The following is a description of a gene set: The process whose specific outcome is the progression of the dendritic spine over time, from its formation to the mature structure. A dendritic spine is a protrusion from a dendrite and a specialized subcellular compartment involved in synaptic transmission. Human Gene Set: GOBP_DENDRITIC_SPINE_DEVELOPMENT species: Homo sapiens, and this is the list of marker genes: LRP8, MAPK6, DLG4, SIPA1L1, FSTL4, ABI3, PTEN, RELN, NCK2, SHANK3, C21orf91, CPEB3, ARHGAP44, CDK5R1, ABI2, DIP2A, ITPKA, HDAC2, PAK3, EPHB2, MAPKAPK5, DVL1, DHX36, WASL, ZNF365, STAU2, CTNND2, EPHA4, CAMK2B, CFL1, LRRK2, LZTS3, FOXO6, ZDHHC15, RAC1, PAK4, CDK5, EFNA1, ARMCX5-GPRASP2, SRGAP2, EPHB3, SDK1, NLGN2, DSCAM (NCBI Gene Id 1826), APOE, PTPRD, GRIN3A, ARF6, GIT1, EEF2K, HDAC6, PTPRS, CDC42, NEURL1, SHANK1, CUX2, BAIAP2, NDP, SRCIN1, NLGN1, WNT7A, CAPRIN1, TANC2, DOCK10, FMR1, ITSN1, SLC30A1, LLPH, IQSEC1, LPAR1, CAMK1, SRGAP2C (NCBI Gene Id 653464), MEF2C, ARF4, PDLIM5 (PDZ and LIM domain 5), ARC, DISC1, PAK2, KIF1A, DLG5, PSEN1, IL1RAPL1, DBN1, CAMK2A (calcium/calmodulin dependent protein kinase II alpha), ZMYND8, IL2, GPRASP3 (G protein-coupled receptor associated sorting protein family member 3), ARHGAP33 (Rho GTPase activating protein 33), DTNBP1, SLC12A5, CAPRIN2, EPHB1, PAFAH1B1, PPFIA2, NGEF